The following is a description of a gene set: Mouse Gene Set: GOBP_DNA_REPLICATION_SYNTHESIS_OF_PRIMER studied in species Mus musculus The synthesis of a short nucleotide polymer using one strand of unwound DNA as a template. The product is usually a RNA molecule between 4-15 nucleotides long that provides a free 3'-OH that can be extended by DNA-directed DNA polymerases. In certain conditions, for example in response to DNA damage, some primases synthesize a DNA primer., and this is the list of marker genes: Polrmt, Primpol, Helb, Pola2, Pola1, Prim1, Prim2 (NCBI Gene Id 98311)